The following is a description of a gene set: Muscular hypotonia (abnormally low muscle tone) manifesting in the neonatal period. Neonatal hypotonia studied in species Homo sapiens Human Gene Set: HP_NEONATAL_HYPOTONIA, and this is the list of marker genes: CWC27, PEX12, GNPTAB, AP4B1, RYR1, BRAF, SPTBN4, MEGF10, CHRNA1, SNORD115-1, SUCLG1, SUMF1, TBC1D24, PEX3, PTRH2, H1-4, NTNG1, PDP1, AFG2A, PDE4D, PSMD12, FIG4, SLC12A6, SMC1A, NONO, SHANK3, HSD17B4, COL12A1, PGAP1, CLPB, MRPS16, VAC14, SLC25A46, OCRL, GABRA2, SYNE1, AP4M1, NEXMIF, MTM1, PWAR1, PEX1, PRDM5 (NCBI Gene Id 11107), MYT1L, AP4E1, IGHMBP2, DLAT, MEG3, RBL2, POMK, VMA21 (NCBI Gene Id 4202), HERC2, NSD1, BIN1, TAF6, PEX16, PEX26, PEX10, GRIA4, ADNP, POMT1, BCS1L, SH2B1, MADD, SLC16A2, CCDC88A, TSFM, FKTN, EEF1A2, CPT2, HADH, SON, ACOX1, B3GALT6, WAC, LAMA2, LYRM4, ARID1B, KCNK9, ALG11, SCN4A, TUBA8, PIEZO2, KANSL1, TBCK, FLNA, SNRPN, CHRND (NCBI Gene Id 1144), SNORD116-1, TMCO1, PAFAH1B1, CHRNE (cholinergic receptor nicotinic epsilon subunit), ZNF469 (zinc finger protein 469), CRPPA, DNAJC19, PEX2, FGFR1 (NCBI Gene Id 84151), SIM1, NDN, MTHFR, MAG, SPOP, DLK1, POMT2, LARGE1, HNF1A, EARS2, ACTA1, NR4A2, GATAD2B, ATXN7, UPB1, ITPR1 (NCBI Gene Id 619543), GATA6, KLHL41, SDHA, LMOD3, COPB1, MT-TT, EIF5A, PWRN1, CNTN1, RPL10, DST, GDAP1, CAMTA1, PDHX, NALCN, DMPK, MAGEL2, HNF4A, WDR19, PEX6 (NCBI Gene Id 5190), NADK2, SLC6A8, TUFM, PHIP, TIMM22, TMEM260, KAT6A, NFIX, MKRN3, MED12, ODC1, STAG1, PCLO, MT-TE, ERCC6L2, GLYCTK, ZNF148, ATP2B3, TPM2 (tropomyosin 2), UQCC2, TNNT1, CHRNB1, PRKAR1B, UNC80, PIK3CD, KNSTRN, CDKL5, VPS13B, PURA, FXR1, PRPS1, PYROXD1, TPM3, ARX, PLCB3, FKRP, MUSK, SOX10, RTL1, FKBP14, TGFB3, COG4, RAPSN, COA6, GOT2, PLOD1, GABBR2, EGR2, TBR1, CASK, PDSS2, SYT1, NPAP1, COL6A1, NEB, FOXG1, USP7, IER3IP1, SLC25A22, CCDC174, VPS53, CFL2, POU4F1, BPTF, MECP2, SLF2, PPP2R5D